Given this list of marker genes LRP4, CHRND, SCN4A (NCBI Gene Id 6329), TTN, CHRNB1, RAPSN, LDB3, DOK7, AK9, MUSK, AGRN, MPV17, CHRNA1, PMP22, COL13A1, MATR3, CHRNE, BSCL2 (BSCL2 lipid droplet biogenesis associated, seipin), here is a description of the gene set: Human Gene Set: HP_ANKLE_WEAKNESS species: Homo sapiens Reduced strength of the muscles that lift or otherwise move the foot at the ankle. Ankle weakness